Given this list of marker genes APOE, ITM2B, APP, PSEN2, CST3, here is a description of the gene set: Amyloid deposition in the walls of leptomeningeal and cortical arteries, arterioles, and less often capillaries and veins of the central nervous system. Human Gene Set: HP_CEREBRAL_AMYLOID_ANGIOPATHY studied in species Homo sapiens Cerebral amyloid angiopathy